The following is a description of a gene set: Human hepatocellular carcinoma (HCC) heterogeneity promotes recurrence and therapeutic resistance. We recently have demonstrated that inflammation favors hepatocyte retrodifferentiation into progenitor cells. Here, we identified molecular effectors inducing HCC metabolic reprogramming, chemoresistance and invasiveness of retrodifferentiated stem cells. Spheroid cultures of human HepaRG-progenitors (HepaRG-Spheres), HBG-BC2, HepG2 and HuH7 cells and isolation of side population (SP) from HepaRG cells (HepaRG-SP) were followed by transcriptomics, signaling pathway analysis and evaluation of chemotherapies. Gene expression profiles of HepaRG-SP and HepaRG-Spheres were enriched in signatures related to cancer stem cells, metastasis and recurrence and showed that HepaRG-progenitors can further retrodifferentiate into a more immature state. The transcriptome from these stem cells matched that of proliferative bad outcome HCCs in a cohort of 457 patients. These HCC stem cells highly expressed cytokines triggering retrodifferentiation and displayed high migration/invasion potential. Importantly, they showed changes in mitochondrial activity with reduced membrane potential, low ATP production and high lactate production. These changes were in part related to angiopoietin-like 4 (ANGPTL4)-induced upregulation of pyruvate dehydrogenase kinase 4 (PDK4), an inhibitor of mitochondrial pyruvate dehydrogenase. Interestingly, up-regulation of ANGPTL4 and PDK4 paralleled that of stem cells markers in human HCC specimens. Moreover, the PDK4 inhibitor dichloroacetate reversed chemoresistance to sorafenib or cisplatin in HCC stem cells derived from four HCC cell lines. In conclusion, retrodifferentiated cancer cells develop enhanced invasion and therapeutic resistance through ANGPTL4 and PDK4. Restoration of mitochondrial activity in combination with chemotherapy represents an attractive therapeutic approach in HCCs. studied in species Homo sapiens Human Gene Set: FEKIR_HEPARG_SIDE_POP_VS_HEPARG_UP from publication Fekir K, Dubois-Pot-Schneider H, Désert R, Daniel Y, Glaise D, Rauch C, Morel F, Fromenty B, Musso O, Cabillic F, Corlu A (PMID 30837223) Genes up-regulated in the cancer stem HepaRG-SP vs HepaRG at 10 days of differentiation, and this is the list of marker genes: SMARCC1, TMEM44, HSPG2, CYP1A1, KLF2, TENT5A, MPZL3 (NCBI Gene Id 196264), USP43, PFKP, IGFBP1, PVT1, KIF23-AS1, FOSL1, ATP2A2, TENM2, MYH9, FLNB, ADGRG1, HES4, FSTL3, SMTN, IRF1, XIST, NFIB, ITGB1, CCAR2, CRYBG2, DCBLD1, DGKA, LAMA5, SNHG12, MT-ND4, MSANTD3P1 (MSANTD3 pseudogene 1), DOT1L, AKAP12, FLNA, UBALD1, TGFB2, CACNB3, HTT, RHEBL1, GNRH1, SACS, PPRC1, TAPBP, TMEM160, LGALS1, ITGA3, LIF, KRT8, SPTAN1, FOSB, SLC5A3, TRRAP, MAFF, TUG1, PLEKHO1, SGMS2, KIAA0408, PACSIN2, JUND, ITGA5, AFDN, EDN1, TNC, EPS8L3, CDH2, RUNX1, ATF3, CFL1, COL4A1, LCAT, GPAT3, FAT1, VCAN (NCBI Gene Id 7902), PMEPA1, MAFK, ABCC2, ITPRIP, ANGPTL4, VPS37B (NCBI Gene Id 79720), TRIP10, PDLIM7, DNAJB5, SNX27, AHR, SRPX2, PIEZO1, UNC13D, NES